Given this list of marker genes Terb2, Rbbp9, Crebl2, Tmprss11f, Map10, Zfp738, Tmem255a, Dbt, Zfp1008, Abcc4, Tex56, Cog3, Six4, Gfra2, Cyp4a31, Pde12, Elmod2, Cldn6, Epas1, Slc39a12, Hnrnpr, Runx1t1, Rabgap1l, Gab3, Ccdc167, Cxcr4, Ophn1, Clec16a, Zfp729a, Cep97, Dhdds, Zfp935, Rnf26, here is a description of the gene set: studied in species Mus musculus Mouse Gene Set: MIR_135B_3P from publication Chen Y, Wang X (PMID 31504780) Genes predicted to be targets of miRBase v22 microRNA mmu_miR_135b_3p in miRDB v6.0 with MirTarget v4 prediction scores > 80 (high confidence targets).